Given this list of marker genes Wnt2b, Maged1, Agt, Agtr2, Pax2, Sox8, Tgfb1, Lhx1, Sall1, Mdk, Agtr1a, Stox1, Pax8, Bmp4, Gja1, Ctnnb1, Pik3cd, Mmrn2, Vegfa, Gdnf, Itgax (integrin alpha X), Gata3, Smo (NCBI Gene Id 319757), Six4, Wnt5b, Sox9, Fgf2, Hoxb7 (NCBI Gene Id 15415), Six1, Agtr1b (angiotensin II receptor, type 1b), Egf, Lif, Nog, Lgr4, Abl1, Alox12, Lbx2, Lcn2, Wnt4, Ar, Pdgfra, Sirt6, Grem1, here is a description of the gene set: Any process that activates or increases the frequency, rate or extent of morphogenesis of an epithelium. Mouse Gene Set: GOBP_POSITIVE_REGULATION_OF_MORPHOGENESIS_OF_AN_EPITHELIUM species: Mus musculus